The following is a description of a gene set: Mouse Gene Set: LEE_BMP2_TARGETS_DN studied in species Mus musculus Genes down-regulated in uterus upon knockout of BMP2. from publication Lee KY, Jeong JW, Wang J, Ma L, Martin JF, Tsai SY, Lydon JP, DeMayo FJ (PMID 17515606) The process of implantation, necessary for all viviparous birth, consists of tightly regulated events, including apposition of the blastocyst, attachment to the uterine lumen, and differentiation of the uterine stroma. In rodents and primates the uterine stroma undergoes a process called decidualization. Decidualization, the process by which the uterine endometrial stroma proliferates and differentiates into large epithelioid decidual cells, is critical to the establishment of fetal-maternal communication and the progression of implantation. The role of bone morphogenetic protein 2 (Bmp2) in regulating the transformation of the uterine stroma during embryo implantation in the mouse was investigated by the conditional ablation of Bmp2 in the uterus using the (PR-cre) mouse. Bmp2 gene ablation was confirmed by real-time PCR analysis in the PR-cre; Bmp2fl/fl (termed Bmp2d/d) uterus. While littermate controls average 0.9 litter of 6.2+/-0.7 pups per month, Bmp2d/d females are completely infertile. Analysis of the infertility indicates that whereas embryo attachment is normal in the Bmp2d/d as in control mice, the uterine stroma is incapable of undergoing the decidual reaction to support further embryonic development. Recombinant human BMP2 can partially rescue the decidual response, suggesting that the observed phenotypes are not due to a developmental consequence of Bmp2 ablation. Microarray analysis demonstrates that ablation of Bmp2 leads to specific gene changes, including disruption of the Wnt signaling pathway, Progesterone receptor (PR) signaling, and the induction of prostaglandin synthase 2 (Ptgs2). Taken together, these data demonstrate that Bmp2 is a critical regulator of gene expression and function in the murine uterus., and this is the list of marker genes: Ly75 (lymphocyte antigen 75), Ddx18, Necap1, Tmx1, Recql, Tipin, Sdad1, Cyp3a44, Medag, Gtf2e1, Thumpd3, Dhfr, Idh3a, Nup205, Foxk2 (forkhead box K2), Pprc1, 2310057M21Rik, Tsr2, Nol10, Dbf4, Purb, Nol9, Lsm8, Pkdcc, Rps24, Firrm, Exoc3l2, Blm (NCBI Gene Id 12144), Edem1, Gmps, Akirin1, Smyd5, Dot1l, Mars1, Lbhd1, Ddi2, Yae1d1, Ak2, Slc19a1, Mto1, Tnfrsf12a, Krtdap, Chordc1, Hmgcr, Dnajc3, Fpgs, Riok3, Prss35, Ppid, Peg12, Ldlr (low density lipoprotein receptor), Usp31, Timmdc1, Mtap, Gja1, Heatr1, Fam118b, Nup153, Clns1a, Pwp1, Ssb, Taf5, Eva1c, Prkab2, Hdac4, Gmfb, Rnps1, Rxra, Flvcr1 (feline leukemia virus subgroup C cellular receptor 1), Snrnp40, Med8 (mediator complex subunit 8), Nup37, Shmt2, Aldh5a1, Stip1, Cdyl (chromodomain protein, Y chromosome-like), Rpa1, Ddx21 (DExD box helicase 21), G3bp1, Ppp2r1b, Cops8, Ccne2, Nars2, Prkci, Mb21d2, Ccnyl1, Hdac1-ps, Qtrt2, Ror1, Sema6d, Slc7a6, Cdc6, Pgap1, Luc7l, Polr1b, Gfm1, Aen, Gins1, Pgd, Kazald1, Slc16a1, Nup50, Creld2, Naa20, Naa50, Amotl2, Zfp131, Xpo5, Umps, Golt1b, Rbm19, Snrpa1, Cenps, Eaf1, Cks1b, Tex30, Dhx29, Jarid2, AI506816, Parp1, Slc39a6, Supv3l1, Cycs, Arl6ip6, Uba2, Dnaja2, Cdca7, Mad2l1, Ccne1, Noc4l, Ptgs2, Bora, Mrpl20, Haus5, Clic6, Mrps18b, Wnt6, Smarca5, Cpsf6, Dis3, Bysl, Prss28, Mllt3, Zfp948, Pfdn4, Pds5a, Pafah1b2, Larp1, Nop56, Il1r1, Plekhg4, Agpat5, Mcts2, D030056L22Rik, Dact1, Nup107, Mdn1, Hspa14, Raph1, Fam149a, Mthfd1l, Lyar (Ly1 antibody reactive clone), Gstcd, Donson, Fut8, Ldha, Rpp40, Dhx33, Ahsa2, Bmp2, Zc3h8, Mcm10, Serpinb9b (NCBI Gene Id 72011), Odc1, Fubp1, Eef1e1, Cluh, Pno1, Parm1, Ankrd26, Sec23ip, Mcm6, Vegfa, Cep192, Hsp90aa1, Ruvbl2, Afg2a, Ube2f (ubiquitin-conjugating enzyme E2F (putative)), Tab3, Hmgn5, Fignl1, Eif2s2 (NCBI Gene Id 99435), Etnk1, Nabp1, Mns1, Ephb2, Ung, Utp18, Cct3, Aass, Esf1, Sfpq, Nifk, Rnd3, Ahsa1, Ncapd3, Pinx1, Cry1, Noc2l, Xpot, Nop58, Hus1, Wdr36, Nol11, Ptcd3, Dcbld1, Nectin3, Rpf2, Cdr2, Tcerg1, Urb2, Timm8a1, Pdxp, Cdk7 (NCBI Gene Id 328323), Tardbp, Ebna1bp2, Srfbp1 (NCBI Gene Id 67222), Cul3, Cox18, Cct6a, Wee1, Pcmt1, Ppp1r8, Faim (Fas apoptotic inhibitory molecule), Ltv1, Mrpl18, Sgo1, Usp53, Gmnn, Zfp148, Exosc6 (NCBI Gene Id 97442), Kpna1, Cox10, Rad23b (NCBI Gene Id 78352), Prps1, Lnpk, Col14a1, Tiam1, Dus4l, Rasgrp1, Fastkd2, 2700038G22Rik, Smad7, Asf1b, Thop1, Slc20a1, Exosc1, Enc1, Nip7, Rcc1l, Kpnb1, Psmc3ip, Tomm20, Dimt1, Mfsd2a, B4galt5, Id1, Tlr3, St8sia2, Mtrr, Nav3, Rrp15, Adamts2, Lrpprc, Dna2, Haus3 (HAUS augmin-like complex, subunit 3), Yaf2, Tmem167 (transmembrane protein 167), Qrsl1, Trmt6, Ddx39a, Fam136a, Pnpt1, Bend3, Nup88, Ddx20, Rps6ka6, Coq10b, Gas5, Srm, Pgam5, Rrn3, Usp24, Pgam1, Eif3j1, Srsf10, Slc35d1, Manf, Mctp2, Ssr1, Snai1, Pdf, Iars1, Tra2a, Tbl3, Hsph1, Hdhd2, Enoph1, Lrr1, Cand2, Slc25a13, Acp1, Zmiz1, Snora65, Prmt7, Hspa5, Lsm6, Fam210b, Gps1, Rpl7l1, Pde3b, Arxes1, Col22a1, Dhodh, Prrx2, Lmnb2, Wdr18, Ncbp1, Bccip, Nin (NCBI Gene Id 73198), Gch1, Skp2, Nab2, Opa1, Fkbp4, Dnaja4, Lpgat1, Obi1, Rpp30, Ndc1, Nt5c3, Me1, Pwp2, Wdr46, Grwd1 (glutamate-rich WD repeat containing 1), Mlec, Wdr75, Eloc (NCBI Gene Id 98484), Ran, Nrn1, Tbrg4, Strap, Psmd12, Rrp12, Uchl3, Dusp9, Slc11a2, Adamts9, Idi1, Dnaaf2, Mmachc, Usp46, Naa15, Jcad, Ptx3, Hspa8, Nqo2, Cep76, Foxn2, Prl8a2, Trip13, Eif1a, Amd1, Fanca, Gemin6 (gem nuclear organelle associated protein 6), Tcof1, Nudt5, Fgf7, Cse1l (NCBI Gene Id 98761), Utp15, Mgat2, Pfn2, Sf3b3, Wdr5, Gspt1, Pcsk5, Sqle (NCBI Gene Id 20775), Rad17, Tmod2 (tropomodulin 2), Ydjc, Prl3c1, Daam2, Csrnp2, 4930503L19Rik, Phlda2, Cacybp, Synpo2, Ndp, Dnmt1, Ppan, Pank3, Nle1, Fam98a, Fancb, Plk4, Chek1, Prelid3b, Eif2b3, Mogs, Farsb, Prkg2, Mrpl50, Nol4l, Piga, Brca1, Pim3, Cdc73, Phgdh, Uba3, Coq7, Psph, Bop1, Gemin5, Leo1, Srsf1, Usp45, Vma21 (NCBI Gene Id 67048), Cdc25a, Rps6kb1, Rcc1, Nmd3, Asns (NCBI Gene Id 27053), Pdss1, Mis18a, Nvl, Casp8ap2, Nfatc2ip (nuclear factor of activated T cells, cytoplasmic, calcineurin dependent 2 interacting protein), Jmjd6, Serpinb9, Tmem97 (transmembrane protein 97), Nipal1, Mcm4, Exoc5, Nolc1, Rgcc (regulator of cell cycle), Hells, Usp1 (NCBI Gene Id 230484), Sacs, Lman1, Txnrd1, Acod1, Ctnnbl1, Apex1, Rbmxl1, Alg3, Mtf1, 1810009A15Rik, Orc6, Polr1f, Mcm3, Prpf4b, Cstf3, Nemp1, Uhrf1, Chn1, Tfdp1 (transcription factor Dp 1), Ptrh2, Cinp, Akr1b1, Mcm2, Nup35, Spdl1, P4ha2, Pfas, Fads3, Zmym1, Dbr1 (NCBI Gene Id 83703), Dck, Dclre1b (DNA cross-link repair 1B), Mrps2 (mitochondrial ribosomal protein S2), Pof1b, Ccdc86, Cad (carbamoyl-phosphate synthetase 2, aspartate transcarbamylase, and dihydroorotase), Hspa9, Taf1d, Cyp51, Secisbp2, Ier5, Ptprg, Mir17hg (Mir17 host gene (non-protein coding)), Rpa2, Sav1, Cbx2, Nme1, Suv39h1, Dnajc2, Zcchc10, Bzw1, Haus7, Shisa3, Epb41l1, Dctd, Nup43, Dctpp1, Brix1, Fastkd1, Oxnad1 (NCBI Gene Id 69703), Them5, Pxdc1, Ska3, Cdc45, Adora2b, Znrd2, Mir1949, Psmd5, Utp4, 1810055G02Rik, Neto2, Mre11a, Cxcl14, Wdr4, Cactin, Kmt5a, Rnf4, Ints2, Nat10, Ass1, Vkorc1l1, Ezh2, Rnf138, Cdk2ap1, Ythdc2, Snu13, Rtel1, Bmper, Uchl5, Hbegf, Cnn3, Sdf2l1, Cct8, Hsd17b7, Atad3a (ATPase family, AAA domain containing 3A), Nampt, Prss12, Melk, Snhg1, Timm23, Usp10, Wdr74, Clspn, Bambi, Appbp2, Spryd7, Ackr3, Fen1, Tmtc1, Etf1, Utp20, Wt1, Simc1, Slc7a1, Ptn, Nhp2, Snhg3, Psat1, Tomm70a, Drd4, Wdhd1, Carnmt1 (NCBI Gene Id 67383), Ihh, Nol8, Nudcd2, Mak16, Tfrc, Qsox2, Cenpq (NCBI Gene Id 83815), Phf5a, Slc2a3, Tdg, Pin1, Acot11, L2hgdh, Mthfd1, Cenpw, Gart, Pole2, Pus3, Moap1, Gar1, Nars1, Mettl16, Agfg1, Orc4, Cct7, Rbm12, Otud6b, Wdr77, Atad5, Ilf2, Tmem199, Jph1, Trappc4, Taf4b, Nucks1, Fra10ac1, Fam111a, C1qbp, Pdgfc, Anp32e, Rbm3 (RNA binding motif (RNP1, RRM) protein 3), Polr1e, Mpi, Serpinb6b, Ddx27, Nup155, Hnrnpab, Zmynd19, Kcmf1, Srpk1, Tmed5, Bhmt, Jak1, Ndufaf4, Wdr76, Tgoln1, Tbx3, Rwdd4a, Fscn1, Polrmt, Nkrf, Tank, Polr1a, Pdcd11, Cenpi, Cstf2, Mrm3, Pa2g4, Pmpca, Atic, 2810408I11Rik, Gnl3, Ppa1, Tmem33, E2f7, Noa1 (NCBI Gene Id 67056), Aurka, Ctps1, Nt5e, Angpt1, Scoc, Tmem30a, Rad51ap1, Trmt10c, Rrm1, Cd38, Foxred1, Pcgf6, Ruvbl1, Mtrex, Lsm3, Pop1, Rrp8, 2010204K13Rik, Vrk1, Tarbp1, Larp4, Nup93, Suv39h2, Fstl3, Knop1, Rpl41, Utp25, Ifrd1, Naf1, Ppif, 2810004N23Rik (NCBI Gene Id 97436), Xpo4, Nudcd1, Nomo1, Timm10, Tars2, Kctd13, Ttll4, Taf2, Slf1, Ttf2, Szrd1, Txnl1, Fga, Enah, Tedc2, Pspc1, Nup160, Runx1 (NCBI Gene Id 12394), Hand2, Prmt3, Kti12, Srsf7, Ciapin1, Kpna2 (karyopherin subunit alpha 2), Cisd1, Wdr12, Ngef, Ehd1, Ddx51, Rras2 (related RAS viral (r-ras) oncogene 2), Srsf3, Dnajb11, Gla, Wdr43, Mapk6, Nup58, Sh3pxd2a, Chaf1b, Utp6, Exosc8, Tnfaip2, Nln, Rbmx2, Pde12, Aoc1, Gpd1l, Pgk1, Hspa4, Ak4, Pus7l, Phf20l1, Nup85, Pole4, Notum, Kpna4, Map7d2, Htra2, Mphosph10, Exo1, Fkbp5, Gtf2e2, Seh1l, Xpo1, Msh6, Zdhhc13, Syncrip, Retsat, Id3, S100a8 (S100 calcium binding protein A8 (calgranulin A)), Chd1, Ttk, Dph2, Irak3, Pum3, Gtpbp4, Nop2, E2f3, Fam227b, Ddx56, Arxes2, Adam12, Gtpbp10 (GTP-binding protein 10 (putative)), Hk2, Rif1, Sinhcaf, Lrrc59, Bub1, Heatr3, Psmd6, Fastkd5, Csrnp1, Wnt4, Limk1, Mex3a, Nop16, Ergic2, Mms22l, Mrps22, Tdo2, Serpine1, Gjb2, Rab32, Ppat, Eif2s1, Smc3, Epha4, Rangrf, Adi1, Zwilch, Lrp12, Wdr55, Mllt11, Rbp7, Haus6, Sct, Rcc2 (NCBI Gene Id 72534), Abce1, Kcnd3, Shmt1, Topbp1, Dlat, Klf5, Dnph1, Orc2, Pclaf, Rad51, Atad2, Hspe1, Nsun2, Dut, Aifm1, Slc41a2, E2f8, Mybbp1a, Rrp1b, Mcm7, Slc16a3, Pbdc1, Abhd10, Ints11, Cdt1, Noc3l, Uap1, Gnptab, Basp1, Urb1, Snapc3 (NCBI Gene Id 77634), Apln, Tmem69, Elac2, Actl6a, Tac2, Zwint, Krr1, Nus1, Ppm1d, Dnaaf10, Slc25a32, Dancr, Wdr3, Mcm5, Unc5b, Paxip1 (NCBI Gene Id 55982), Mmgt1, Dlk2 (NCBI Gene Id 106565), Baz1a, Rrs1, Prmt1, Dnaja3, Cip2a, Timm17a, Hdac2, Prmt6, Nasp, Naa25, Lin54, Hspd1, Tsr1, Pnn, Trim59, Tnfaip8, Sptlc2 (serine palmitoyltransferase, long chain base subunit 2), Fst, Ranbp1, Dkc1, Nup54 (NCBI Gene Id 269113), Btaf1, Glod4, Slc30a2, Traip, Dtl, Fosl1, Igsf11, Dnajb1 (DnaJ heat shock protein family (Hsp40) member B1), Timm9, Fkbp3, Cyc1, Map3k7, Ywhag, Mrto4, Ecrg4, Klhl29, Rrm2, Uck2, Dnajc21, Emilin2, Hoga1, Prpf40a, Isg20l2, Polr3k, Plaa, Mtfr1, Cyp11a1, Steap1, Psme3, Shq1, Xrcc6, Lsm12, Mat2a, Tomm5, Arhgap20, Mthfd2, Yars2, Trub1, Rps9, Smchd1, Eif4e, Azin1, Hat1, Noct, Elovl2, Ubqln1, St6galnac4, Chchd4, Samd4, Usp39